The following is a description of a gene set: studied in species Homo sapiens Human Gene Set: GAO_LARGE_INTESTINE_24W_C2_MKI67POS_PROGENITOR from publication Gao S, Yan L, Wang R, Li J, Yong J, Zhou X, Wei Y, Wu X, Wang X, Fan X, Yan J, Zhi X, Gao Y, Guo H, Jin X, Wang W, Mao Y, Wang F, Wen L, Fu W, Ge H, Qiao J, Tang F (PMID 29802404), and this is the list of marker genes: FOXC1, JAG2, ESAM, RAMP3, FLT1, SLCO2A1, UBE2C, NDC80, UBE2T, EBF1, PHF19, CD93, LMCD1, FABP4, PIMREG, TM4SF1, MMRN2, PRC1, ANLN, PODXL, CASP10, NRP1, ARHGEF6, ECSCR, GIMAP6 (GTPase, IMAP family member 6), GIMAP7, LRRC8C, PECAM1, CDH5, LRRC32, RRM2, CLEC14A, TOP2A, TFPI, TSPAN7, SERPINE2, CLEC3B, GNG11, PCAT19, TPX2, CENPW, CCNA2, NOS3, ADGRF5, KDR, TACC3, ROBO4, TROAP, CYYR1, CCNB2, NUF2, APLNR, RHOH, MMRN1, SEC14L1, ACVRL1, ENG, HIP1, INPP5D (inositol polyphosphate-5-phosphatase D), CDK1, EMCN, F2R, MYCT1, CD248, NUSAP1, GIMAP4 (NCBI Gene Id 55303), CDKN3, MXD3, KIF20B (kinesin family member 20B), AURKB, CCNB1, ASPM, PTTG1, JAM2, EGFL7, ARAP3, FZD4, PTPRB, SOX18, CENPF, BIRC5, VWF, LDB2, HYAL2, DIPK2B, TK1, CLDN5, CALCRL (NCBI Gene Id 10203), KNSTRN, NCAPD3, TAL1, TRAIP, HSPA12B, HMCN1, RGCC, NRN1, DLGAP5, BGN, IQGAP3, PALMD, CDC20, H4C3, MKI67, TIE1, CD34, PLVAP, ARHGAP29, RAMP2, APOLD1, CRIM1-DT, HEG1, ERG, SHE